The following is a description of a gene set: species: Mus musculus Negative regulation of TCF-dependent signaling by WNT ligand antagonists Mouse Gene Set: REACTOME_NEGATIVE_REGULATION_OF_TCF_DEPENDENT_SIGNALING_BY_WNT_LIGAND_ANTAGONISTS, and this is the list of marker genes: Sost, Dkk4, Kremen2, Kremen1, Dkk2, Dkk1, Lrp5, Lrp6